The following is a description of a gene set: Anaplasia (unfavorable histology) is associated with therapy resistance and poor prognosis of Wilms tumor, but the molecular basis for this phenotype is unclear. Here, we used a cDNA array with 9240 clones relevant to cancer biology and/or kidney development to examine the expression profiles of 54 Wilms tumors, five normal kidneys and fetal kidney. By linking genes differentially expressed between fetal kidney and Wilms tumors to kidney morphogenesis, we found that genes expressed at a higher level in Wilms tumors tend to be expressed more in uninduced metanephrogenic mesenchyme or blastema than in their differentiated structures. Conversely, genes expressed at a lower level in Wilms tumors tend to be expressed less in uninduced metanephrogenic mesenchyme or blastema. We also identified 97 clones representing 76 Unigenes or unclustered ESTs that clearly separate anaplastic Wilms tumors from tumors with favorable histology. Genes in this set provide insight into the nature of the abnormal nuclear morphology of anaplastic tumors and may facilitate identification of molecular targets to improve their responsiveness to treatment. species: Homo sapiens Genes up-regulated in Wilm's tumor vs fetal kidney. from publication Li W, Kessler P, Williams BR (PMID 15531917) Human Gene Set: LI_WILMS_TUMOR_VS_FETAL_KIDNEY_2_UP, and this is the list of marker genes: NCAM1, NAP1L1, H2AZ1, STMN1, NGFR, DDX1, CRABP2, NSD2, EZH2, PRIM1, HEXB, VCAN, HMGA2, IGF2, ENC1, SLC43A3, MEOX1, HOXA10, MYCN, NCAM2, HOXA1 (NCBI Gene Id 3198), BIRC5, IGF1, SET, EFNB3, ROR2, HOXD9